The following is a description of a gene set: Human Gene Set: GENTILE_RESPONSE_CLUSTER_D3 DNA damage caused by UV radiation initiates cellular recovery mechanisms, which involve activation of DNA damage response pathways, cell cycle arrest and apoptosis. To assess cellular transcriptional responses to UVC-induced DNA damage we compared time course responses of human skin fibroblasts to low and high doses of UVC radiation known to induce a transient cellular replicative arrest or apoptosis, respectively. UVC radiation elicited >3-fold changes in 460 out of 12,000 transcripts and 89% of these represented downregulated transcripts. Only 5% of the regulated genes were common to both low and high doses of radiation. Cells inflicted with a low dose of UVC exhibited transcription profiles demonstrating transient regulation followed by recovery, whereas the responses were persistent after the high dose. A detailed clustering analysis and functional classification of the targets implied regulation of biologically divergent responses and suggested involvement of transcriptional and translational machinery, inflammatory, anti-proliferative and anti-angiogenic responses. The data support the notion that UVC radiation induces prominent, dose-dependent downregulation of transcription. However, the data strongly suggest that transcriptional repression is also target gene selective. Furthermore, the results demonstrate that dose-dependent induction of cell cycle arrest and apoptosis by UVC radiation are transcriptionally highly distinct responses. studied in species Homo sapiens from publication Gentile M, Latonen L, Laiho M (PMID 12907719) Cluster d3: genes progressively down-regulated in WS1 cells (fibroblast) through 12 h irradiation with high dose UV-C., and this is the list of marker genes: PPP2R1B, FOXJ3, TUBGCP3, TLK1, DKK1, COIL, ZNF623, DR1, SERTAD2, E2F2, CDR2, SLC25A44, TRAPPC8, C2CD2, ADNP, TRIM13, POLE2, AMD1, UNG, RHOB, ELF4, ZFAND5, GINS1, SIAH2, TIPARP, ZMIZ1, PODXL, TAF11, TNFAIP8, RNF4, TM4SF1, KIF23, NR2F6, POM121, CCN1, RIPK1, MCL1, LSM14A, PLK4, BNIP2, SCHIP1, MBD2, CRKL (CRK like proto-oncogene, adaptor protein), BMI1, SLBP, CNOT2, CKS2, HERPUD1, BLCAP, SSH1, BRD8, RPP40, CDC6